Given this list of marker genes Ralgapa1, Tube1, Rad52, Pithd1, Arel1, Ppp5c, Kifbp, Zmat2, Tomm7, Mcts2, Tsen2, Tmtc3, Myo9a, Tgds, Fcf1, Cnot11, Taf5, Dld, Coa8, Crls1, Cherp, Leo1, Nsun5, Cacul1, Tafazzin (tafazzin, phospholipid-lysophospholipid transacylase), Fbxl12os, Cln8, Mrfap1, Cycs, Zfp988, Dph5, Znhit6, Zeb1, Cdk8, Lrrcc1, Marf1, Slc35b4, 1700086L19Rik (NCBI Gene Id 74284), Srfbp1, Timm23, Bbs5, Ctnnbl1, Prkar1b, A930005H10Rik, Ndufs5, Ncoa5, Utp25, Dcaf8, Smu1, Phaf1, Rnf111, 4930540M05Rik, Klhdc9, Fam229b, Senp8, Cox4i1, Slc31a1, Asb7, Chek1, 2510039O18Rik, Wdr7 (NCBI Gene Id 56065), Psmb6 (NCBI Gene Id 19175), Tfpt, AF357399, Dnajc19, Gm27021, Elp3, Gne, Fkbp15, Gm19710, Cyb5d2, Golga7, Zzef1, Parg, Itfg1, Mir484, C230035I16Rik, Pbrm1 (polybromo 1), Dpy30, Clec16a, Faf1, Usp48, Ccdc174, Dnajc9, Tbc1d23 (NCBI Gene Id 98049), 5430402O13Rik, Phkb, Eef1g, Eif3d, Cep290, Gnl3, Cwf19l2, 2810408A11Rik, Pdss2, Ddi2, E4f1, Plcxd3, Prpf31, Eif4b, Faap100 (Fanconi anemia core complex associated protein 100), Ciao3, 9430091E24Rik (RIKEN cDNA 9430091E24 gene), Dnaaf5, Etfrf1 (NCBI Gene Id 67636), Dnai7, Neurl4, Mrpl15, Map4, Czib, Cept1, Naa30, Ggcx, E230029C05Rik, Dnase1l1, Rps16, Lins1, Eed, Ubr1, Mks1, Gm43391, Dram2, Pkn2, Emc8, Pdpr, Bag5, Hax1, Slc25a19, Fktn, Lsm4, Pigk, Ipo8, Nudt9, Tti2, Zc3h15, Snord13, Dmac1, Rbm33, Csnk1g2, here is a description of the gene set: from publication Yevshin I, Sharipov R, Kolmykov S, Kondrakhin Y, Kolpakov F (PMID 30445619) Genes containing one or more binding sites for (E4f1) in their promoter regions (TSS -1000,+100 bp) as identified by GTRD version 20.06 ChIP-seq harmonization. species: Mus musculus Mouse Gene Set: E4F1_TARGET_GENES